The following is a description of a gene set: Human Gene Set: GOMF_PEPTIDOGLYCAN_MURALYTIC_ACTIVITY studied in species Homo sapiens A catalytic activity that contributes to the degradation of peptidoglycan., and this is the list of marker genes: PGLYRP4, SPACA5, LYZL6, LYZ, SPACA3, PGLYRP3, SPACA5B, LYG2, LYZL2, LALBA, PGLYRP1, LYZL1, LYZL4, LYG1, PGLYRP2